The following is a description of a gene set: The inositol phosphates IP6 and IP7 are exported from the cytosol to the nucleus. The molecular details of these transport processes remain uncertain. studied in species Homo sapiens part of: Inositol phosphate metabolism Reactome Pathway: IP6 and IP7 transport between cytosol and nucleus, and this is the list of marker genes: NUP42, NUP107, TPR, NUP50, NUP58, NUP205, SEH1L, NUP62, AAAS, NUP188, NUP153, NUP54, NUP37, NUP98, NDC1, NUP160, NUP133, SEC13, NUP43, NUP214, RAE1 (ribonucleic acid export 1), POM121 (NCBI Gene Id 9883), NUP88, RANBP2, NUP93, NUP155, NUP210, NUP85, POM121C, NUP35